The following is a description of a gene set: species: Mus musculus from publication Mori S, Rempel RE, Chang JT, Yao G, Lagoo AS, Potti A, Bild A, Nevins JR (PMID 18922927) Up-regulated genes in the B lymphocyte developmental signature, based on expression profiling of lymphomas from the Emu-myc transgenic mice: the Pre-BI stage. The Emu-myc transgenic mouse has provided a valuable model for the study of B-cell lymphoma. Making use of gene expression analysis and, in particular, expression signatures of cell signaling pathway activation, we now show that several forms of B lymphoma can be identified in the Emu-myc mice associated with time of tumor onset. Furthermore, one form of Emu-myc tumor with pre-B character is shown to resemble human Burkitt lymphoma, whereas others exhibit more differentiated B-cell characteristics and show similarity with human diffuse large B-cell lymphoma in the pattern of gene expression, as well as oncogenic pathway activation. Importantly, we show that signatures of oncogenic pathway activity provide further dissection of the spectrum of diffuse large B-cell lymphoma, identifying a subset of patients who have very poor prognosis and could benefit from more aggressive or novel therapeutic strategies. Taken together, these studies provide insight into the complexity of the oncogenic process and a novel strategy for dissecting the heterogeneity of B lymphoma. Human Gene Set: MORI_PRE_BI_LYMPHOCYTE_UP, and this is the list of marker genes: HSPBP1, CKS1B, E2F8, CDK1, DTL (NCBI Gene Id 51514), MGST2, MCM7, MTHFD2, SQLE, MCM6, TUBB, RAMP1, GRB7 (NCBI Gene Id 2886), PSAT1, ADGRG3, SOCS2, ANKRD33B, SLC29A1, TUBB4B, CDKN1A, MELK, H2AX, KPNA2, HMGB3, KIF4A, IGLL5, TUBA1A, TUBA1B, MIF, CDCA5, NUCKS1, LEF1, DBI, IDE, ACTN4, ENPEP, EMB, RACGAP1, CCNB2, GZMA, SSBP4, HMGN2, RRM2, H2AZ2, ANP32E, H2AC8, CDCA7 (cell division cycle associated 7), CDCA3, PRDX4, SMARCC1, RRM1, RAD51, FCER1G, KANK3, LIG1, STMN1, CCL5 (C-C motif chemokine ligand 5, NCBI Gene Id 8147), DNTT, PRC1, MKI67, GSTT2, HJURP, SMC4, RASA4B, RAN, CDC20, TXN, AURKA, TOP2A, MCM2, NCAPH, MPEG1, LMNB1, HNRNPAB (NCBI Gene Id 3182), TTK, EMP1, ENG, PHGDH, RBBP4, UBE2C